Given this list of marker genes SAMD7, CFI (NCBI Gene Id 3426), CWC27, KIZ, TLCD3B, RPGR, EFEMP1, CFH, here is a description of the gene set: Hypoautofluorescent retinal lesion Decreased amount of autofluorescence in the retina as ascertained by fundus autofluorescence imaging. Human Gene Set: HP_HYPOAUTOFLUORESCENT_RETINAL_LESION species: Homo sapiens